Given this list of marker genes GATA3, BCOR, CCNQ, INTU, ZEB2, TP63, DHCR7, MKKS, WT1, HOXA13, UBR1, MNX1, here is a description of the gene set: studied in species Homo sapiens Septate vagina The presence of a vaginal septum, thereby creating a vaginal duplication. The septum is longitudinal in the majority of cases. Human Gene Set: HP_SEPTATE_VAGINA